Given this list of marker genes Lox, Src, Myocd, Hip1, Hip1r, Lrp1, Ptpn2, here is a description of the gene set: Mouse Gene Set: GOBP_REGULATION_OF_PLATELET_DERIVED_GROWTH_FACTOR_RECEPTOR_BETA_SIGNALING_PATHWAY Any process that modulates the frequency, rate or extent of platelet-derived growth factor receptor-beta signaling pathway. species: Mus musculus